The following is a description of a gene set: studied in species Homo sapiens Cadherin-19 (CDH19, also known as CDH7L2) is a classical type II cadherin. The human CDH19 gene is a part of the cadherin gene cluster at the chromosomal bands 18q22-q23, together with CDH7 and CDH20. At the plasma membrane, CDH19 associates with alpha-catenin (CTNNA1), beta-catenin (CTNNB1), gamma-catenin (JUP) and delta catenin (CTNND1), like other classical type I and type II cadherins. CDH19 possesses five extracellular cadherin domains and, like other classical cadherins, is thought to play a role in the establishment of homotypic cell-cell adhesions during formation of adherens junctions.<br><br>In rat, the expression of Cdh19 overlaps with the expression of the neural crest cell marker Sox10. In mouse, it was shown that Sox10 transcription factor, essential for migration of neural crest cells during formation of the enteric nervous system, binds to the Cdh19 gene promoter and stimulates Cdh19 transcription. Cdh19 knockdown results in retarded sacral migration of neural crest cells, while re-expression of Cdh19 partially rescues retarded migration of Sox10-null neural crest cells. CDH19 is a specific marker of Schwann cell precursors.<br><br>During angiogenesis, in response to monocyte chemotactic protein 1 (MCP-1, also known as CCL2 or C-C motif chemokine 2), CDH19 transcription is directly stimulated by ZC3H12A (MCPIP, for MCP-1 induced protein). CDH19 was found to be a target of microRNA miR-197-5p. The circular RNA hsa_circ_006220 was shown to sponge miR-197-5p and lead to upregulation of CDH19 mRNA and protein levels. Circular RNAs that possess multiple microRNA binding sites act as sponges that, by binding to microRNAs, prevent these microRNAs from associating with their target mRNAs.<br><br>Both upregulation and downregulation of CDH19 have been reported in cancer and it has been proposed to play both oncogenic and tumor-suppressive roles, depending on the cancer type. CDH19 mRNA is upregulated in clear-cell sarcoma and correlates with a hypomethylated profile. In glioblastoma, CDH19 is upregulated in cancer stem-like cells. In colorectal tumors, CDH19 is upregulated compared to normal tissue. In triple negative breast cancer, CDH19 was proposed to play a tumor suppressor role. A homozygous deletion of the CDH19 gene was reported in a portion of chondrosarcoma tumor samples. <br> part of: Regulation of Expression and Function of Type II Classical Cadherins Reactome Pathway: Regulation of CDH19 Expression and Function, and this is the list of marker genes: CDH19, CTNNB1, ZC3H12A, JUP, SOX10, CTNND1, CTNNA1